Given this list of marker genes Iscu, Slc11a2, Alas2, Ncoa4, Hif1a, Hamp2, Lcn2, Ifng, Hamp, Slc39a14, Bola2, Glrx3, Abcb7, Ndfip1, Erfe, Scara5, Fxn, Smad4, Acvr2b, Atp13a2, Hpx, Bmp6, Ireb2, Slc11a1, Hmox2, Egln1, Gdf2, Fthl17e (ferritin, heavy polypeptide-like 17, member E), Aco1, Trf, Ftl1, Atp6v0d1, Atp6ap1, Ftmt, Cp, Sod1 (NCBI Gene Id 319325), Tmem199, Fbxl5, Steap3, Hephl1, Slc40a1, Fth1, Hmox1, Hfe, Slc39a8, Atp6v1a, Tfrc, Myc, Tfr2, Steap4, Frrs1, Sco1, Ccdc115, Bmyc, Cisd1, Atp6v1g1, Smad5, Steap2, Mon1a, Hjv, Ttc7, Nubp1, Meltf, B2m, Mecr, Slco2b1, Smad1, Cybrd1, Cyb561a3, Neo1, Picalm, Tmprss6, Cyb561, Atp6v0a2, here is a description of the gene set: A homeostatic process involved in the maintenance of a steady state level of iron ions within a cell. Mouse Gene Set: GOBP_INTRACELLULAR_IRON_ION_HOMEOSTASIS studied in species Mus musculus